Given this list of marker genes GNMT, UROS, DHFR, FOLR2 (NCBI Gene Id 2350), FOLR3, FTCD, FTCDNL1, FOLR1, SLC46A1, SLC19A1, TYMS (NCBI Gene Id 7298), MTHFS, DHFRP1, IZUMO1R, here is a description of the gene set: Human Gene Set: GOMF_FOLIC_ACID_BINDING studied in species Homo sapiens Binding to folic acid, pteroylglutamic acid. Folic acid is widely distributed as a member of the vitamin B complex and is essential for the synthesis of purine and pyrimidines.